Given this list of marker genes MCHR1, PLPPR3, RAD51, PIP4K2C, H4C3, CEP135, CCDC15, MTX2, ATRX, POU3F1, CENPI, TRAF3IP3, ARIH2, WNK1, TFDP2, TST (NCBI Gene Id 96794), DHFR, DGKG, RASSF7, CREG1, PDCD1, ARHGEF11, SEL1L3, KCNS3, CARD9, SNX10, HOXB9, KIF22, LINC02637, NEK7 (NCBI Gene Id 148565), PDLIM5, ARL6IP4, RNASE2, PIAS3, TVP23B, SSX4 (SSX family member 4), METAP2 (NCBI Gene Id 10988), TNS3, IQCE, GNA12, SLC31A1, GLUD2, H3C10, NUP43, OSTF1, HOMER3, SPDL1, ZMYM5, AP5Z1, SLC15A2, KRT10, MTCL1, FAM131A, FADS1, RBM5, FGL1, TANK, MRE11, SCHIP1, MYBPC3, HOXA3, NDUFB8, XPC, TRAF6, SEMA5A, PCDHGC3, BMPR1A, MFAP3, ACP2, RSRC1, SLC46A3, WNT5A, WRAP73, AAK1, AK2, SLIT3, FKBP1B, CHST5, MSH3, SLC39A1, HUS1, NFATC1, FRY, CACNA1I, POLR2C (RNA polymerase II subunit C), TLK1, RAD1, ZBED4, DOCK9, RTL8C, MAFG, BEX3, DCK, TOP3A, TCP10L3, SGCB (NCBI Gene Id 6443), PDS5B, RYBP, OGFOD3, PRKAB1, UGGT1, NCAM2, CNOT4, ARHGEF40, AHI1 (NCBI Gene Id 54806), HOXA5, TMEM14A, RWDD1, ERG28, PPP1R3A (NCBI Gene Id 5506), PLOD1, HOXB5, CCDC28A, PKN2, RER1, ETFDH, ANKRD42-DT, TIMM23, PIN4, TRPM8, ZFR2, COMMD4, CHMP2B, FBXO28, MAPK10, PABPC1P3, ADCY7 (NCBI Gene Id 113), CTBP2, DCUN1D4, GP5, YWHAB, TGS1, SELENOP, RGSL1, NEIL3, ST3GAL4, CDK5R1, SDS, MACIR, AQP3, EXOSC4, UGT2B15, GPR137B, PLCB3, PRPS1, IDE, CAT, B4GALT4, ZNF768, EML2, DDR1-DT, CSTF1 (cleavage stimulation factor subunit 1), FANCA, APTX, NFE2, CPVL, TCEAL9, PAK1IP1, SPINK2, PKNOX1, GUCA1B, TMPO, TXNIP, SLCO3A1, HOXA6, SERINC3, CA7, PRLH, DLEU2, TMT1A, HNRNPH3, PURA, LHFPL6, ST3GAL2, PINK1, CNR1, TJP2, ADAM12, CA12, BAX, IP6K1, LIMS1, CYB5RL, CEP104, HTRA1, GPR135, ZBTB43, CDK2, EXOSC7, SC5D, SSX2, TOP1, ZNF213-AS1, RESF1, GP6, MAP3K7, RBM25, UBE2K, ZXDC, KMT5B, EGFL6, STAG2 (STAG2 cohesin complex component), GK, IL15, PDE3A (phosphodiesterase 3A), IGF2BP2, PPP1R26, SMC4, RTN2, PTPN4, SH3GLB2, UBR2, TIMM17A, TBC1D17, ACO1, HOXB6, SCGB1D1, CAPRIN2, NIPA2, CETN1, KIF3A, COL4A5, HMGB1, CD84, YME1L1, ALX1, MAP3K5, GABBR2, GTSE1, CHRM5, TRIM38, MAGEA9, PTPN11, GPR21 (G protein-coupled receptor 21), NFATC2IP, MBNL2, RAD50, ITGAX, VOPP1, SH3BP2, KYNU, EPHA1, HSD17B4 (hydroxysteroid 17-beta dehydrogenase 4), SIX6, DPY19L2P2, NIPBL, ERP44, WWP1, CLN8, PBX3, SMARCD3, MEIS1, SEPTIN8, HOXA4, CCL23, VCP, ABHD2, ATF5, TRAPPC3, HOXB3, HOXA7, SP3, LGR4, CHGB, KPNA4, PI4KB, TM2D3 (TM2 domain containing 3), RSRP1, SOX13, UNKL, GHITM, RAB38, SH3GL1, CFLAR, ASRGL1, PDGFD, SRGN, COL1A2, GOT1, ARHGAP11A, POLR1G, CRP (NCBI Gene Id 1401), CTH, DNAJB2, ORC6, NCOA3, GNRHR, STX6, LAMA2, HOXB2, HOXA2, ZNF322, TRIM31, MYO1C, RAPSN, PPARGC1A, MLLT10, SPG7, RBKS, HOXA10, ALK, LUZP4, DZIP3, HOXA9, DST, FBXO42, MPHOSPH8, HMGN5, NFE2L2, HFE, ATM, EDDM3A, ARFIP1, AP3S2, HSP90AA1, PPP1R8, TMCO1, CACNA2D1, SON, ZMYM2, PLSCR2, MAN2A2, CAVIN2, ZNF780B, TNC, DPEP2, LEPROT, PLA2G4A, CELF1, HNRNPA1P37, EMC9, FEM1B, SSX2IP, AGBL5, INSIG1, here is a description of the gene set: The 'NPM1 signature 3': genes up-regulated in pediatric AML (acute myeloid leukemia) with mutated NPM1 compared to the AML cases with intact NPM1 and MLL. Somatic mutations in nucleophosmin (NPM1) occur in approximately 35% of adult acute myeloid leukemia (AML). To assess the frequency of NPM1 mutations in pediatric AML, we sequenced NPM1 in the diagnostic blasts from 93 pediatric AML patients. Six cases harbored NPM1 mutations, with each case lacking common cytogenetic abnormalities. To explore the phenotype of the AMLs with NPM1 mutations, gene expression profiles were obtained using Affymetrix U133A microarrays. NPM1 mutations were associated with increased expression of multiple homeobox genes including HOXA9, A10, B2, B6 and MEIS1. As dysregulated homeobox gene expression is also a feature of MLL-rearranged leukemia, the gene expression signatures of NPM1-mutated and MLL-rearranged leukemias were compared. Significant differences were identified between these leukemia subtypes including the expression of different HOX genes, with NPM1-mutated AML showing higher levels of expression of HOXB2, B3, B6 and D4. These results confirm recent reports of perturbed HOX expression in NPM1-mutated adult AML, and provide the first evidence that the NPM1-mutated signature is distinct from MLL-rearranged AML. These findings suggest that mutated NPM1 leads to dysregulated HOX expression via a different mechanism than MLL rearrangement. from publication Mullighan CG, Kennedy A, Zhou X, Radtke I, Phillips LA, Shurtleff SA, Downing JR (PMID 17597811) studied in species Homo sapiens Human Gene Set: MULLIGHAN_NPM1_SIGNATURE_3_UP